Given this list of marker genes FCGR2B, HLA-E, FCGR1A, IGHE, FCGR3A, IGHG1, FCGR2C, FCGR1BP, FCGR2A, FCGR3B, here is a description of the gene set: species: Homo sapiens Human Gene Set: GOBP_ANTIBODY_DEPENDENT_CELLULAR_CYTOTOXICITY Cytolysis of target cells by natural killer cells, eosinophils, neutrophils, monocytes, or macrophages following engagement of antibodies bound to the target cells by Fc receptors on the effector cells.